Given this list of marker genes CAV1, LMNA, SKI, NAA10, KCNJ6, here is a description of the gene set: Human Gene Set: HP_MINIMAL_SUBCUTANEOUS_FAT species: Homo sapiens Minimal subcutaneous fat